The following is a description of a gene set: Human Gene Set: GOBP_AMINO_ACID_SALVAGE Any process which produces an amino acid from derivatives of it, without de novo synthesis. species: Homo sapiens, and this is the list of marker genes: APIP, BHMT2, ENOPH1, BHMT, ADI1